The following is a description of a gene set: Human Gene Set: GSE11961_FOLLICULAR_BCELL_VS_MARGINAL_ZONE_BCELL_UP To obtain insight into the genetic basis of the increase of functional activity of memory B cells over time, we compared the gene expression profiles of day 7 and day 40 NP-specific/IgG1 memory B cells, GC B cells and plasma cells in immunized WT mice and naïve B cells, before and after activation in vitro. species: Homo sapiens from publication Kaji T, Ishige A, Hikida M, Taka J, Hijikata A, Kubo M, Nagashima T, Takahashi Y, Kurosaki T, Okada M, Ohara O, Rajewsky K, Takemori T (PMID 23027924) Genes up-regulated in follicular B cells versus marginal zone B cells., and this is the list of marker genes: CD7, DDR2 (NCBI Gene Id 4921), POT1, RSBN1, CEPT1, MAP6, AKAP7, NEU3, CFB, SEMA3B, TMEM68, CEMIP2, FOXN1, ABCB9, PAPSS2, CEP72, IFT88, NEUROG3, ABCB7, H1-4, ECPAS, C4orf46, ARL6IP6, HOXC13, MEF2C, GABRD, BOC, ADGRD1, TYROBP, RIC8A, EMSY, CPN2, CNKSR2, RNF144A, NCF2, CCP110, DSCAM, SOS2, BMPR2, GDAP1L1, SSTR2, LYN, PGLYRP2, DCK, HIF3A, DTX1, PRIMA1, FAM167A (family with sequence similarity 167 member A), DCP2, PAK6, SLC30A4, FMR1, ELMOD3, CTSS, AHRR, NCK1, LGALS8, SERPINH1, SLC5A11, PTGFR, FOXO3, TRIB2, STK39, GRIN2D, USP28, UBE2Q1, LIMD2, SESN3, PEX19, C16orf87, C3orf80, CACNG3, BBS7, SLC16A3, IGLON5 (NCBI Gene Id 402665), ADCK1, CNRIP1, DUSP14, RNF128 (NCBI Gene Id 79589), ORC3, LDB3, HNRNPA0, USP6NL, ZNF808, MAP4K3, CDCP1, BTRC, CEP57L1, USP9Y, SWT1, OPA1, GPR68, ZFAND4, CREBRF, SCN2B, DUSP28, CACNA2D1, DAB2, CCL25 (NCBI Gene Id 6370), TEX44, SCN2A, VOPP1, PAQR9, STAP1, P2RY12, ARL15, CKS2, PYROXD1 (NCBI Gene Id 79912), CPLX1, GRM2, OSGIN2, ATP2B2 (NCBI Gene Id 491), RASAL2, SMURF2, ARFGEF2, PRAM1, UBR1, NOS2, FBXL13, DUOXA1, SPRTN, KLHL20, MTHFD2 (NCBI Gene Id 10797), GLCCI1, NIPA2 (NIPA magnesium transporter 2), KRT80, PLPPR5, FGD3, ZNF597, TSPAN2, SDK1, MRC2, MMP9, CAPZA1, CC2D2B, RSAD2, TLR1, SHPRH, TMEM168, CRBN, MYO1H, TASL, KRT85, THBS2 (thrombospondin 2), GGT1, CXCL14, NAPG, SPRING1, FRMD5, CMPK2, TFEC, ESPL1, TMEM179B, NXPE3, CLIC4, AZGP1, GMPR, MSANTD1, RAB11B, JCAD, PDCD6, TMEM132C, SLAMF6, ZKSCAN8P1, MS4A7, CATSPER1 (cation channel sperm associated 1), RAB1A, DNAH5, SMCO1, CHSY1, FAM32A, SLC8A2, GPR143, AGTR1, NHLH2, ACTL10, GPR88, TSPAN13, ADAM10, PURB (NCBI Gene Id 5814), NCALD, DDR1, HCCS, GPR155, NRBF2 (nuclear receptor binding factor 2), HECW1, GALM, SPINK5, SETDB2, WDR44, PPP6R2, OTOS, RNF11, RINL, ATF7IP2, THUMPD2 (NCBI Gene Id 80745), TRAPPC6B, TRIQK, GPAM, SLC2A3